Given this list of marker genes STARD5, HCFC2, RGS19, WDR1, VARS1, SARS1, PLPP5, OSM, RARA, EHD4, GPR180, ASPSCR1, FXR2, NRP2, ING1, DCAF8, MIIP, CPT1A, XKRX, REEP4, TSPAN2, CASP8, SNAPC2, NOP9, CYP1B1, WDR81, PIAS2, VPS29, PCK2, GNA11, ALPK2, MED19, NXPE3, EIF4G1, SLC4A11, TRIP10, PFKFB2, KYAT1, ARFIP2, RAB1A, SYPL1, CERS4, SEMA7A, IFRD2, KAT7, LAMTOR1, ITGA7, ERGIC3, GEM, CHM, MPST, RPN2 (NCBI Gene Id 6185), MCU, PC, UBL4A, WBP1L, GALT, TNFSF14, RPS18, ATXN7L3 (NCBI Gene Id 56970), YARS1, AREL1, MAGEA11, WIPI2, DAP3, DNAI3, ITGA3, ZDHHC18, EID2, CELA1, IL1RN, TUBB, RNASEK, TUBA3C, CDC14B, TXNIP, KAT5, GADD45A, USF1, DDX10, GLMP, MEN1, SMPD1, NEK6, ITGB7, OGG1 (NCBI Gene Id 93577), SLC16A2, SH3RF1, PIWIL2, LUZP1, MED10 (mediator complex subunit 10), ORAI3, PLP2, UBE2Q2, NCBP2AS2, TCF25, DENND3, ZC3H10, DACH2, AKIRIN2, TXNDC5, YIF1B, MIF4GD, TCEANC2, SMIM14, HAUS8, TMEM176A, GABRA5, KCTD17, PNPLA2, ADAM9, IBA57, NME6, RUVBL2, BANF1, PCBP4, TMEM176B, GRK5, UCP2, KDELR1, PARP16, CTSD, IL1R1, EEFSEC, CDIPT (CDP-diacylglycerol--inositol 3-phosphatidyltransferase), SPECC1, DNAJA4, PARVG, CXCL1, DDX49, EIF4E3, TAF6L, ZFP36L2, THRA, RGS1, ACBD6, USP22, AHRR, TTC7A, PRRC1, YWHAG, CCNI, BCAR1, GPR108, TPBG, CCDC107, PMP22, PECAM1, ARHGEF10, SNAPC1, VDAC1, TRMT112, ARHGDIB, BARHL1, RNF167, PBX2, SLC30A4, IGFBP4, CLPTM1, CCDC34 (NCBI Gene Id 91057), BIN3, GFER, HERPUD1, ATP2A3, GLA, GPR15, NRG3, CUL7, FKBP2, ASCC1, EIF2B2, NIPAL1, LPO (lactoperoxidase), RNF125, RER1, MUL1, MAEA, ATP6V0E1, SPI1, PPM1J, SAC3D1, ALDOA, PAQR8, FGG, UTP14A, GCNT1, COX18, STIP1, RASSF7, TRAM1, SDR39U1, FBXO21, BEND4, RAB11A, UTY, FABP1, RCC1, CA5B, SCPEP1, here is a description of the gene set: species: Homo sapiens TGF-beta3 produced by developing Th17 cells induces highly pathogenic T cells that are functionally and molecularly distinct from TGF-beta1-induced Th17 cells. The microarray data represent a distinct molecular signature for pathogenic versus non-pathogenic Th17 cells. from publication Lee Y, Awasthi A, Yosef N, Quintana FJ, Xiao S, Peters A, Wu C, Kleinewietfeld M, Kunder S, Hafler DA, Sobel RA, Regev A, Kuchroo VK (PMID 22961052) Human Gene Set: GSE39820_CTRL_VS_TGFBETA1_IL6_IL23A_CD4_TCELL_DN Genes down-regulated in comparison of untreated CD4 T cells versus those treated with TGFB1, IL6 and IL23A.